The following is a description of a gene set: studied in species Homo sapiens Abnormality of the genital system Human Gene Set: HP_ABNORMALITY_OF_THE_GENITAL_SYSTEM An abnormality of the genital system., and this is the list of marker genes: TMEM216, FANCB, F11, DAZ1, TSC1, CHRNA3, GTF2I, MEG3, VAMP7, SEPTIN12, FYB1, DNAAF2, AUTS2, TEKT3, FOS, WAS, SETBP1, BTG4, KIT, ACR, CEP57, WDPCP, PRLR, F8, NDUFB11, PSMB10, SALL4, SLC26A2, WNT9B, RXYLT1, IER3IP1, TUBB2B, OFD1, SRCAP, NDUFB7, ZNF365, IKZF1, SMC3, MINPP1, PNKP, ANKLE2, MCFD2, IRF6, RASA2, CREBBP, GTF2H5, SIL1, NKX2-1, TRIP13, ARSL, INTU, SOST, WEE2, TOGARAM1, STK36, PLG, MT-ND5, SIAH1, SNORD115-1, SSR4, BRAF, THOC2, WASHC5, EIF4H, ERCC3, SOX11, H1-4, DNAAF4, MSH6, CEP152, CAMSAP1, CDY2A, UNG, GABRD, FLT4, CDC42, RPS17, PEX6, CFAP69, DTYMK, CDC14A, LIG3, MEIOB, NANOS1, VPS50, FBXO11, MT-ND4, F2, NEDD4L, DCHS1, GTF2IRD1, DHX37, SMS, PIGP, GALC, GPR101, MASP1, PLXND1, ABCB7, SDHC, NELFA, DLK1, ABCD4, PRKACB, HOXA13, TNFAIP3, TNRC6B, RPL27, MBD5, ACTB, GH1, GREM1, STAG3, TONSL, UBAC2, RPL11, FBLN1, LHX3, TWIST1, DDB1, MBTPS2, IRX5, CACNA1G, DNM2, SLX4, SPATA16, RPS26, SPINK2, SOX5, DPH2, PEX13, TAF6, EIF2B2 (NCBI Gene Id 8892), CFAP251, UBR7, RPS6KA3, CLCN4, SNORD116-1, KPNA7, HSD3B2, ODAD2, HRAS, COQ2, RBM8A, HES7, BMPR1A, NEK10, AURKA, PHIP, GJB2, POFUT1, OCA2, JAM3, CFAP221, AMH, GREB1L, FAT4, NNT, HCCS, ORC6 (origin recognition complex subunit 6), DNA2, SLC19A2, CFAP91, B4GALT7, CLCN3, MGME1, PDE11A, FBXW7, DNAJB13, BICC1, DNAH9, CCNO (cyclin O), MYH3, DNAI2, MSH3, PHF8, GGN, PACS2, MAGEL2, EIF2B3, EFNB1, DNAJC19, NIPBL, ABCD1 (NCBI Gene Id 215), RPL10L, INPP5E, LMOD3, MLXIPL (NCBI Gene Id 51085), WT1, STUB1, HBB, TP63, PIGG, ERAL1, AKAP3, SOX4, SRD5A2, DNAH1, NBN, MT-TF, RPS29, HNRNPH1, ODAD1, LIG4, SEMA4A, LHX4, BPTF, TNFSF4, CDON, NCF1, MPV17, LGR4, DGCR6, MNS1, IFIH1, SRA1, SSX1, SOS1, RPS20, MLH1, IRF4, GP1BA, PLVAP, SLC29A3, CAV1, GFM2, TUBA1A, RBMX, SCYL2, COMT, CITED2, ACTL7A, CLPP, MED12L, TTC8, IFT81, BCL10, HLA-DRB1, UPB1, DDB2, CEP112, TUBB8, RNF113A, CEACAM3 (NCBI Gene Id 1084), PRPS1, FXR1, BBS5, ALG1, STS, PADI6, DDX3Y, SATB2 (NCBI Gene Id 80104), LAS1L, PHKA2, IGKC, SUFU, SOX3, RPGRIP1, PLCZ1, AXIN2, AP1S2, DMXL2, TBX6, ZBTB16, HNRNPR, TBX22, CAMK2A, SKIC3, WDR35, TRPM3, PHF21A, BUD23, IL10, AFF4, PCNT, BRWD3, KIF21A, CUX1, ATN1, B4GAT1, TSHB, SMARCA2, PRORP, POLE (NCBI Gene Id 80252), PSMC1, SQSTM1, ATR, TALDO1, TMEM270, TPR, PLIN1, EFEMP1, CHD7, CLEC7A, EIF2S3, SHOC1, PDE4D, ATIC, RPS15A, SALL1, IPO8, BIN1, PPFIBP1, HERC2, ESCO2, ATP6V0A2, POU3F3, FANCE, PLAGL1, POLR1A, GAD1, HNF1A, AGGF1, CDH2, HSD17B4, CFAP61, AKT1, NBEAL2, IL23R, NSUN2, DPM2, G6PC3, ODAD3, ARHGAP31, MIF, MXI1, TWIST2, HS2ST1, ZP1, CSPP1, DLL3, METTL27, RSPO1, ARID1A, XRCC2 (NCBI Gene Id 7516), KASH5, GJA5, MAB21L1, MYOD1, RBM10, CCN2, HNRNPK, USP26, DPAGT1, DDX6, RTN2, SLC25A22, CATSPER2, GSTM3, PPM1B, HYLS1, PLAAT3, CDKN2C, CDKN2A, MAP3K7, FZD2, RPS28, ASTL, TNFRSF1A, LRPPRC, SMARCD1, GJB3, ZP2, ESAM, RPS4Y2, HMGA2, LRP2, AURKC, DNAJB11, PIGN (NCBI Gene Id 23556), PITX2, POLR3A, CHEK2, CDC6, ACTL9, CCDC22, FAM111A, FANCI, MT-TS2, F7, PHOX2A, STAT5B, ADAMTS15, BUB1B, PDPN, FBXL4, LMAN1, TTC5, MRE11, GHR, CHEK1, PMM2, USP48, H19, FRAS1, BRF1, LHX1, HLA-DPB1, BAZ1B, FGF20, DOCK8, FBN1, OPA1, TTC29, RNU7-1, KMT5B, SAMHD1, MRPS22, CASK, IDH2, DGCR8, BBS12, RIPK4, CDT1, NDP, ESS2, TRRAP, RERE, IL17F, YWHAE, ALDH18A1, RREB1, CDC42BPB, EVC2 (NCBI Gene Id 132884), RRAS, MTM1, ALG5, TXNRD2, STAT4, VHL, ALOX12B, KIF7, NF1, DNMT3A, TINF2, KDM5D, PNLDC1, RPL9, CLDN2, PALB2, KLHL10, RFWD3, AIP, SEMA3E, TBX1, XPC (NCBI Gene Id 7508), PATL2, BAX, TBX15, SKI, HTRA2, FLNB, DHDDS, SMARCA4, IL17RD, FSHR, IRF2BP2, XPA, FANCF, OTUD6B, FGFR1, TGFBR1, SOX9, AXL, PWAR1, FANCM, PIEZO1, STT3B, MT-TW, MSTO1, LHCGR, KANSL1, TGIF1, H6PD, TCOF1, MEFV, GMPPB, TTI2, KLHL15, AGK, SUN5, FOXF1, APC2, H4C5, ATPAF2, PAICS, COQ6, MAD2L2, SLC18A3, FOXL2, MC2R, HSPG2, SERPINE1, BBIP1, AHDC1, ZFPM2, NR5A1, NDNF, CCDC146, GCNA, CCDC141, CHST14, CCDC39, PPARG, ALDH1A2, LMBR1, SMG8, KISS1, GMNN, LSM11, RAPSN, TRIM8, GBA1, PLA2G2A, CDH1, SPRED1, CYP11A1, TERB2, PCSK1, NONO, PTPRJ, EBP, CNBP, KDM5C, AARS2, SIN3A, TRIM32, ASH1L, HERC1, GTF2E2, COL4A6, FGF8, UBE2T, RFC2, HPS4, BICRA, BLOC1S5, CHD6, FAS, ANAPC7 (anaphase promoting complex subunit 7), DOK7, SDHB, MCM8, NOP10, MOV10L1, MT-TH, SEC23B, DCTN4, HROB, STEAP3 (STEAP3 metalloreductase), CHD4, DBH, TWNK, FOCAD, FGF10, FERMT1, ADAT3 (adenosine deaminase tRNA specific 3), STRA6, PEX19, GATA3, STAG1, COL7A1, BMP15, UBE4B, MSH4, ALG8, HSD17B3, ESR2, C4A, DNAAF11, THSD1, CHP1, CFAP58, OCRL, ATP6AP2, PRKACG, CTNS, PRKDC, FLI1, ERAP1, ERCC4, SYNJ1, BRCA1, CILK1, ENSG00000288330, ZFTA, F13A1, SHH, TRIP4, TSPY1, FGFRL1, COL1A1, ARMC12, PLCB4, SLC6A17, MT-TQ, CCNQ, EPG5, LMOD1, CCDC34, STXBP1, TLR2, CCND1, TUBB, CFTR, IFT74, FREM2, FCGR2C, MCM5, PTCH1, SLC25A13, TSPYL1, ADNP, POMK, NUMA1, KAT6B, KDM3B, NLRP3, SCN2A, LARS2, ADAR, FREM1, TMEM70, CLIP2, CCDC8, MT-TL1, PRTN3, MCTP2, PROK2, PAFAH1B1, DCLRE1C, NME8, SPACA1, INVS, TBCD (tubulin folding cofactor D), SPAG17, VEGFC (vascular endothelial growth factor C), TASP1, IRF5, DIAPH2, FIGLA, UPF3B, DYNC2H1 (NCBI Gene Id 79659), CT55, DPF2, LRIG2, NUP107, KLHL41, GALT, HLA-DPA1, B9D1, BNC1, ALG12, THOC6, BBS1, UBR1, DGCR2 (NCBI Gene Id 9993), SPRY4, GP1BB, SLC11A1, SOS2, DNAJC21, ERMARD, POMGNT2, PIK3R1, TUBB3, CORIN, GPC6, RAB3GAP1, CDH23, FKTN, CYB5A, TGFB3, PEX10, PUM1, ERCC2, CEP19, ATM, RAB18, NEB, PRRX1, TRAIP, EIF2B4, GLI3, CDC20, IFT172, EXT2, PHACTR1, NABP1, TDRD9, CHRM3, SLC37A4 (NCBI Gene Id 84965), LHB (NCBI Gene Id 3972), KIF14, TP53, PAX7, IGHG2, GAS2L2 (growth arrest specific 2 like 2), MNX1, LIPE, MADD, TLE6, MRPS7, KMT2A, PYCR1, RAF1, RAD51D, RPGR, ORC1, CTCF, GATA1, DCX, GCLC, LUZP1, IL12A, POLA1, INSL3, EDNRA, CLMP, VPS37D, BDNF, NHP2, F13B, MED12, MTOR, IL12A-AS1, SRRM2, DACT1, SMOC1, KLLN, IFT80, SHOC2, PTCH2, FANCA, CDKN2B, CD96, NUP88, PORCN, GSC, GNRH1, KIAA0753, COG5, CHRNG, PINK1, H4C9, ZMIZ1, CRIPTO, LEPR, KCNJ6, MECP2, CDH11, TGFB2, BMPR1B, FOXA2, NTHL1 (nth like DNA glycosylase 1), ARX, KISS1R, SYCP3, WIPF1, AGA, POLR1B, USP9X, RNASEL, FGA, PPP1R12A, BPY2, IDH1, CTSH, GGPS1, HPS5, STT3A, CFAP74, TMEM237, STRC, NECTIN1, SPEN, RECQL4, COLEC11, HBA1, VCY, PEX14, ADA2, CAMKMT, RAC3, LIMK1, WDR62, HNF1B, UBE2A, SMO, GTF2IRD2, DAZ3, MED13L, GLYCTK (glycerate kinase), SNRPN (small nuclear ribonucleoprotein polypeptide N), ARNT2, CASZ1, RBBP8, RTEL1, ZP3 (zona pellucida glycoprotein 3), SUCLG1, RAB23, SERPINA1 (serpin family A member 1), STAC3, GATAD2B, NPHP4, H4C11, ATP6V1A, WNT10A, RNF216, PIK3C2A, DZIP1, PI4KA, ISL1, SLC31A1, KLF1, SCLT1, POLG2, EIF5A, NEK1, EPHB2, CCDC28B, COL3A1, KCNU1 (NCBI Gene Id 157855), NME5, ETFB, RELA, GNAO1, SYCE1, ODC1, RARB, TBL1XR1, BLTP1, USP8, FGB, FARSB, C2CD6, MCM9, ADARB1, AXIN1, RYR1, RIT1, RORA, AAGAB, SCAPER, VPS4A, SIX6, MAP2K2, TERB1 (telomere repeat binding bouquet formation protein 1), TREX1, POMT2, DHODH, PIK3CA, RNASEH2A, MSH2, TTR, DNAH17, WNT5A, UFD1, LRRC23, TNXB, WWOX, PSMC3IP, SLC3A1, POLR3H, NODAL, PPP2R3C, RNASEH2B, CEACAM6, EP300, NHLH2, RPL35A, SGPL1, ALMS1, MUSK, GLI2, POLR3K, NF2, PANX1 (NCBI Gene Id 24145), RSPO2, LYN, SAMD9, CDC45 (cell division cycle 45), TBL2, BARD1, SEC23A, IFNGR1, CLIC2, CWC27, RRM2B, BMP6, COL5A2, HHAT, PAX3, DPY19L2, DNAAF5, SETD1A, PIEZO2, RABL3 (NCBI Gene Id 285282), CRPPA, DPM1, TMEM107, FARS2, PEX5, RNF212, SC5D, SLC9A3 (NCBI Gene Id 6550), ATP5F1E, MEGF8, TKT, APC, TAPT1, NR3C1, VPS35L, REV3L, JMJD1C, HARS2, DYNC2I2, BLM, SPTBN1, B3GALNT2, GRIN2B, KCNA1, NDN, MYH11, HBA2, PHKG2, GRIA3, IL17RA, DLC1, TBC1D20, GATA5, SMAD4, CYP19A1, CATSPER1, TAF4, SLFN14, SPRED2, ARL6IP6, POGLUT1, ANGPT2, KATNIP, DNAH7, IQCN, TTC21A, MAF, KEAP1, NEXMIF, KCNH1, BTK, HPRT1, RFX7, MSX1, NKAP, FBXO43, B3GLCT, PRKCZ, GBA2, GNB2, BBS2, DNAAF6, COL14A1, SOX2 (NCBI Gene Id 6657), SDCCAG8, RPS10, VANGL1, OGT, FANCG, TCTN2, SEMA3A, PDHA2, GUCY1A1, PKD1, HLA-DQB1, ALK, EHMT1, TRPV6, HSF2BP, CFAP70, RLIM, CEP164, AK7, CFAP65 (NCBI Gene Id 255101), SIM1, GATA4, HS6ST1 (heparan sulfate 6-O-sulfotransferase 1), FOXC1, DIAPH1, MAB21L2, RIN2, FTO, MEI1, BCOR, PUF60, SLC35A2, MT-CO1 (NCBI Gene Id 4512), MCC, RCBTB1, TBX3, ATP7B, CARS1, SLC16A2 (solute carrier family 16 member 2), TSC2, GATA6, ERCC5, RTTN (rotatin), GNE (NCBI Gene Id 81868), BUB1, DPP9, PARN, RNU12, LONP1, KLHL40, CTDP1, LZTFL1, WFS1, KAT5, NDUFS4, MYMK, RAD21, UCHL1, FIP1L1, CDC73, CTBP1, PARK7, UBA1, JAG1, DCAF17, KCNAB2, LMNA, ARMC5, MYC, BRCC3, BRDT, CC2D2A, PMFBP1, KCNQ1, GDF1, SYCP2L, ERCC8, ANOS1, COL4A5, C14orf39, WNT3 (Wnt family member 3), CEP120, EBF3, PGR (NCBI Gene Id 5241), DPYSL5, ZIC2, HESX1, SYNE1, MT-ATP8, SRY, LMX1B, SMARCB1, AHSG, FGFR2, EIF4A2, SRC, HDAC8, DDX3X, APOA1, MDFIC, VPS13C, PIGL, USP9Y (NCBI Gene Id 8287), POLR1D, PMS1, IFT27, RPL31, ATP5MK, BRIP1, RIPPLY2, GRIP1, ZSWIM7, MOGS, MECOM, MYF6, DNAH11, CDKN1B, ARMC9, PTRH2 (NCBI Gene Id 51651, peptidyl-tRNA hydrolase 2), F5, PRMT7, CDCA7, IL1RAPL1, DMRT1, GNA11, DAG1, CTC1, PBX1, PEX12, FCGR2A, NOTCH3, NSMF, EWSR1, SMAD3, HOXD13, RNF135 (ring finger protein 135), CCDC32 (coiled-coil domain containing 32), HMOX1, TRANK1, AR, TLR4, MOG, TBC1D24, RBM28, FANCC, ANTXR1, MAPRE2, NIN, TYMP, CFAP43, GLE1, RSPH1, ZFHX3, FGFR3, PRIM1, HJV, HSFY1, CDK8, RPS19, RPL26, PTEN, CBL, TRIM28, WRAP53, BBS9, KDM1A, HID1, PTPN11, DNAAF1, GCM2, TGDS (TDP-glucose 4,6-dehydratase), RNU4ATAC, LFNG (NCBI Gene Id 3955), POGZ, CLP1, MKS1, YARS1, SLC32A1 (NCBI Gene Id 140679), RPL10, POU1F1, SLC40A1, CUL7, NEUROD2, TTC12, RNASEH2C, VAC14, CCR6, ORC4, DNAAF3, MT-CO2, PAPSS2, GRM7, MMP23B, ATRX, SETD2, CPLANE1, CDY1, SUZ12, RET, ECE1, HYDIN (HYDIN axonemal central pair apparatus protein), OPCML, ACBD6, ZSWIM6, DNAH8, AKR1C4, HPS6, SEC24C, ALG9, PLAU, DLL1, IGF2, ITPR1, TACR3, TRMT10A, RRAS2, TYMS, REC114, SYNGAP1, ZFP36L2, FKBP6, CUL4B, RSPH9, AIRE, DNM1L, NAB2, EPCAM, AMACR, SLC34A2, USB1, SETD5, ITGB6, NDUFA8, POLR3B, TEX14, TRAF3IP1, DNAH5, PROKR2, BCS1L, MRAS, DKC1, GPC4, FEZF1, ZMYM3 (NCBI Gene Id 9203), CPE, TPM2, KDM5B, BLOC1S3, ROBO1, TBX4, MRAP, GPR161, HOXC13, UBAP1, PREPL, CDKN1A, FGF17, TMEM94, CXCR4, MKRN3, NFIB, STAT3, FIG4, RSPH3, FLG, FASLG, PTPN12, RPS27, SLC25A24, POMT1, IGBP1, NPAP1, KCNN4, DHCR24, TERT, CFAP410, MT-ND6, CIDEC, FOXE1 (NCBI Gene Id 7081), PNPLA6, PAX6, MED25, MESP2, FSIP2, PEX11B, ACTG2 (NCBI Gene Id 72), DISP1, ARVCF, EDEM3, MSH5, PPP1R15B, ERBB2, RPS24, MYLK, SLC35D1, MID1, GDF6 (NCBI Gene Id 9571), RPGRIP1L, NR0B1, TBL1X, MMP2, ADAMTS3, USF3, FAM149B1, MAMLD1, POLR1C, FANCL, DVL3, KMT2D, BBS7, RASGRP2, TCTN3, HFM1, SMARCAL1, FANCD2, SPATA22, SLC30A7, GP6 (NCBI Gene Id 51206), ARL6, MED11, ABL1, ITGA8, SMARCE1, NALCN, ZNF462, OBSL1, FGD1, TRAF3IP2, CCBE1, INSR, GATA2, CYP17A1, PQBP1, ATP6V1B2, ITGB3, TIAM1, KRT5, ATP5F1A, GNRHR, EED, MAP3K1, APOLD1, FOXJ1, KCNQ1OT1, SIX3, OTUD5, KMT2E, DIS3L2, SMCHD1, MYL11, MYT1L, NSD1, ELN, STK33, UQCC2, NPHP3, RARA, ASXL3, AEBP1, MBD4, NOBOX, TFR2, HGD, ALX4, SPINT2, XKRY, BRD4, SYCP2, CAPN15, TOPORS (NCBI Gene Id 641432), CISD2, PEX3, DLX4, GLI1, BRWD1, SPEF2, GRB10, TSGA10, KLRC4, SOX10, MYMX, WBP4, AMHR2, POMGNT1, OPHN1, PEX1, CASP10, GNAS, LETM1, MOS (NCBI Gene Id 4342), DSE (dermatan sulfate epimerase), PWRN1, HEATR3, METTL23, DDX59, JAK3, NKX2-6, DAZ4, KIAA0586, ACTA2, RAD51C, NRAS, NXN (nucleoredoxin), M1AP, CKAP2L, CFAP52, PKD2, FDXR, SLC26A8, SACS, RPL8 (NCBI Gene Id 6132), LMNB2 (lamin B2), CDKN1C, MYRF, GDF9, PALLD, VPS13B, LEP, CATIP, ANTXR2, TGFBR2, MAPK1, B4GALNT1, DYRK1A, TPM4, NPM1, EVC, ZEB2, ARID1B, CYP21A2, ERCC6, RPL18, FDFT1, KDSR, PROP1, FLT1, PODXL (NCBI Gene Id 5420), AKR1C2, BBS4, COL4A1, ETFA, NLRP5, FOXH1, SOHLH1, PDE6D, ODAD4, ARMC2, FUZ, DNAH10, SDHD, MANF, QRICH2, NAF1, SLC26A9, CDKL5, P2RY11, ECEL1, ATP6V1E1, HLA-B, NDUFA6, GAS1, MPLKIP, YY1 (YY1 transcription factor), DYNC2I1, PPP2R1A, OTX2, TARS1, ATP5F1D (NCBI Gene Id 513), PIGS, PRKAR1A, MCIDAS, MUTYH, MT-CYB, KMT2C, FH, NTN1, EIF2B1, NAA10, ZNF699 (zinc finger protein 699), DNAL4, CEP290, NFIX, TOP6BL, RBMY1A1, ZMYND15 (zinc finger MYND-type containing 15), NLRP2, BMP4, SLC6A14, ZMYM2, CTNNB1, SMARCC2, SLC39A4, HEXB (NCBI Gene Id 3074), HDAC4, EMG1, AKT2, B9D2, FLNA, USP7, GJA1, WNT7A, KRAS, HEPACAM, PIGA, FMR1, TXNDC15, ZMPSTE24 (zinc metallopeptidase STE24), SNCA, CAVIN1, XRCC4, TAF4B, BMP2, TEX11, BUB3, POF1B, HCRT, DCC, VWF, MRPS28, TMEM231, MTMR14, MT-ND1 (mitochondrially encoded NADH:ubiquinone oxidoreductase core subunit 1), EZH2, KLF6, PRDM16, FKRP, ITGA2B, PLAG1, GP9, KDM6B, ANKRD11, MDM2, TMCO1, BBS10 (Bardet-Biedl syndrome 10), NSD2, LSS, TBCK, HIRA, IQCB1, MMP14, TCTN1, STAT6, TERC, LMNB1, SPRTN, PRKACA, GFRA1, COG1, PTPN22, PAX2, NR2F2, MEN1, HAMP, ARCN1, ERCC1, MAX, FLRT3, ANAPC1, WRN, GJB4, ATAD3A, TBCE, CCDC62 (coiled-coil domain containing 62), TAC3, TSR2, DHH, CFAP47, PEX2, BRCA2, HIBCH, CPLX1, RPL5, DAZ2, ZNRF3, ZMYND10, POLD1, SNAP29, CFAP298, POC1A, KCNN3, CTU2, PSPH, CTLA4, ATXN8OS, GRIN1, CYP11B2, MCM3AP (NCBI Gene Id 8888), MAD1L1, MKKS, ESR1, HYMAI, SF3B4, DNALI1, HFE (homeostatic iron regulator), FLCN, ZDHHC9, HUWE1, ADH5, SIK1, RAD51, CCDC40, CFAP300, CLCA4, ETFDH, KIFBP (NCBI Gene Id 96724), PDGFRL, RTL1, WDR19, HLA-DQA1, TOE1, NOTCH2, ZFX, PSMD12, GRIA2, AARS1, COLEC10, ZPBP, MYH9, LRRK2, ARID2, PSMB8, SCP2, PTDSS1, IGF1, LAMA5, RNF43, DRC1, STAR, FILIP1, RAC1, TGFB1, PDGFB, DVL1, FSHB, PMS2, WDR11, KAT6A, CENPT, PHF6, HTT, PACS1, DNAH2, ANK1, IL17RC, PHKB, DTNBP1, POLG, DUSP6, STK11, SCN1B, NPHP1, ALKBH8, ADGRG2, RAD50, PEX26, RAB3GAP2, PRDM13, TRAF7, DHCR7, FGG, BSCL2, PML, GANAB, PPP1CB, WNK3, SMAD2, IFT140, CCR1, CBX2, SCUBE3, PRKN, ROR2, CYP11B1, WDR37, IL10RB, POU6F2, SPIDR, ARL2BP, CCDC174, LARGE1, BAP1, MT-CO3, CHD8, TCF12, SLC2A3, RSPH4A, RPL35, XYLT2, REST, DMPK, ZBTB20, SPECC1L, PSENEN, ALOXE3, MAP2K1, WNT4, SOX18, TMEM67, CYLC1, COX7B, SLC25A10, STOX1, COL5A1, CFAP45, CEP41, INPPL1, DNHD1, WNT7B, LARP7, POR, RPS7, DEPDC5, PEX16, RPL15, SMC1A, LRRC56, COL25A1 (collagen type XXV alpha 1 chain), AGPAT2, UBE3B, TCF4, TFAP2A, RAD54B, HPSE2, NKX2-5, GK (glycerol kinase), SPAG1, MT-ATP6, C2CD3, ACTA1, GALK1, TMEM63A, F10, MLH3, LZTR1, GJC2, PTPRF, DYNC2LI1, STX1A, BTNL2, DNAI1, PHGDH, PIGQ, ZPR1, KDM6A (lysine demethylase 6A), DICER1, DNAL1, DNAJC6, KDR, CFAP418, DNAJC30, GPC3, CFAP44, TEX15, CCIN